The following is a description of a gene set: Human Gene Set: HP_ABNORMAL_LUNG_LOBATION species: Homo sapiens Abnormal lung lobation A developmental defect in the formation of pulmonary lobes., and this is the list of marker genes: HIRA, RREB1, WNT3, BUB1B, AKT1, GPC4, FANCB, MEIS2, GDF1, SEC24C (SEC24 homolog C, COPII coat complex component), BUB1, NEK8, FOXF1, FRAS1, NKX2-6, GP1BB, ARVCF, CHUK, PUF60, DHCR7, BUB3, PIGT, TBX1, PLXND1, JMJD1C, LBR, FREM2, RAB34, CC2D2A, NODAL, ZIC3, EMG1, TBX4, WT1, RSPO2, GLI3, CEP57, UFD1, TRIP13, ALG9, GPC3, GRIP1 (NCBI Gene Id 23426), COMT, HYLS1